The following is a description of a gene set: studied in species Mus musculus Reactome Pathway: Ethanol oxidation This event has been computationally inferred from an event that has been demonstrated in another species.<p>The inference is based on the homology mapping from PANTHER. Briefly, reactions for which all involved PhysicalEntities (in input, output and catalyst) have a mapped orthologue/paralogue (for complexes at least 75% of components must have a mapping) are inferred to the other species. part of: Phase I - Functionalization of compounds electronically inferred by orthology from the curated human pathway, and this is the list of marker genes: Adh5, Aldh2, Aldh1b1, Adh4